The following is a description of a gene set: part of: Antimicrobial mechanism of IFN-stimulated genes species: Mus musculus This event has been computationally inferred from an event that has been demonstrated in another species.<p>The inference is based on the homology mapping from PANTHER. Briefly, reactions for which all involved PhysicalEntities (in input, output and catalyst) have a mapped orthologue/paralogue (for complexes at least 75% of components must have a mapping) are inferred to the other species. Reactome Pathway: GBP-mediated host defense electronically inferred by orthology from the curated human pathway, and this is the list of marker genes: Gbp2, Fnta, Gbp5